Given this list of marker genes Nnt, Nans, Eif5b, Serpind1, Tpst1 (NCBI Gene Id 97280), Trip12, Mmp17 (NCBI Gene Id 23948), Mtres1, Hpd, Dnajb11, Pdk4, Egf (epidermal growth factor), Pkia, Vdac2, Nrbp2, Icos, Stmn2, Tshb, Fastkd5, Nop58, Eps15l1, Nxf1, Pdxdc1, Zfp574, Pgap2, Mov10, Slc2a4, Msi1, 2410018L13Rik, Usp22, Snrpb, Zfp444, Fbln1, Lamb3, Stx12, Abcc3 (NCBI Gene Id 76408), Tspan33, 1810037I17Rik, Sf3b5, Rap1gds1, Nfkb1, Ccdc6, Rmc1, Ormdl3, Zfp35, Rpf1, Otub1, Pramel48, Tnfaip8l1, Prkcd, Fabp5, Zfand6, Sgce, Comt, Glmp, Samm50, Mrps34, Nf1, Mageb1, Brip1os, Sema4f, Chchd7, Piga, Mnt, Skap2, Baz1b, Flcn, Dmtn, Sdc1, Sfpq, Pdlim7, Kcnn1, E2f8, Slc35c2, Epb41l4b, Gdi2, Tcirg1, Map3k12, Hoxd4, Ncoa1, Hp, Slc2a1, Zmym4, Cetn2, Pxmp2, Ndufs2, Ranbp9, Mki67, Cavin2 (NCBI Gene Id 20324), Anp32a, St8sia1, Crygb, Hand1, Csnk2a2, Zfyve16, Sbno1, Upk3b, Pdlim1, Igfbp4, Naa30, Cnbp, Abca1, Uba1y, Rnf19b, Ifit1, Eif2b4, Orm2 (NCBI Gene Id 18406), S100pbp, Fgf9, Sptlc2, Gldc, Lrrc58, Ttc17, Sfr1, Sf3a2, Psd, Agrp, Map1s, Tmem222, Myh3, Capn6, Pld2, Utp4 (NCBI Gene Id 21771), Zbtb14, Ppara, Mrpl50, Ucp1, Ahcyl, Sall3, Tbc1d15, Psmd14, Ctcf, Sypl1, Rap1b, Hsd17b2, Dnajb6, Hnrnph2 (NCBI Gene Id 56258), Stk11, Epop, Slc16a2, Psmb5-ps, Dda1, Ptcd3, Mcm3ap, Tiparp, Pvalb, Crisp3, Naalad2, Mkln1, Eya3, Akap8, Hmox2, Aip, Pck2, Mrps5, 1700073E17Rik, Med10, Tulp4, Cyba, Blm (Bloom syndrome, RecQ like helicase), Zfr2, Chd8, Nsd1, Vamp1, here is a description of the gene set: studied in species Mus musculus We combined large-scale mRNA expression analysis and gene mapping to identify genes and loci that control hematopoietic stem cell (HSC) function. We measured mRNA expression levels in purified HSCs isolated from a panel of densely genotyped recombinant inbred mouse strains. We mapped quantitative trait loci (QTLs) associated with variation in expression of thousands of transcripts. By comparing the physical transcript position with the location of the controlling QTL, we identified polymorphic cis-acting stem cell genes. We also identified multiple trans-acting control loci that modify expression of large numbers of genes. These groups of coregulated transcripts identify pathways that specify variation in stem cells. We illustrate this concept with the identification of candidate genes involved with HSC turnover. We compared expression QTLs in HSCs and brain from the same mice and identified both shared and tissue-specific QTLs. Our data are accessible through WebQTL, a web-based interface that allows custom genetic linkage analysis and identification of coregulated transcripts. Genes trans-regulated by the same QTL (quantitative trait loci) in brain and hematopoietic stem cells (HSC). Mouse Gene Set: BYSTRYKH_HEMATOPOIESIS_STEM_CELL_AND_BRAIN_QTL_TRANS from publication Bystrykh L, Weersing E, Dontje B, Sutton S, Pletcher MT, Wiltshire T, Su AI, Vellenga E, Wang J, Manly KF, Lu L, Chesler EJ, Alberts R, Jansen RC, Williams RW, Cooke MP, de Haan G (PMID 15711547)